Given this list of marker genes PLCG1, IQGAP1, BAG4, SYAP1, DAB2IP, EEF1A1, ASCL1 (achaete-scute family bHLH transcription factor 1), GSTP1, DUSP3, PTPN11, CFL1, TPR, STAT5B, INPP5K, SPG21, CAD, SNAI2, ERBB2, AKT1, ERRFI1, ZFP36, GIT1, FOS, SNX6, ZFP36L2, MAPK1, NCL, COL1A1, KNSTRN, BAIAP2, DUSP22, BECN1, PDE8A, PPP1R9B (NCBI Gene Id 84687), MCM7, EGFR, CFLAR, PDPK1, MED1, ZPR1, BLOC1S6, FOXC1, ZFP36L1, VIL1, ERBB4, SOX9, MARS1, CRIPTO, DAB2, PTPN12, MAPK3, GAREM1, here is a description of the gene set: Any process that results in a change in state or activity of a cell or an organism (in terms of movement, secretion, enzyme production, gene expression, etc.) as a result of an epidermal growth factor stimulus. studied in species Homo sapiens Human Gene Set: GOBP_RESPONSE_TO_EPIDERMAL_GROWTH_FACTOR